The following is a description of a gene set: from publication Fu W, Ergun A, Lu T, Hill JA, Haxhinasto S, Fassett MS, Gazit R, Adoro S, Glimcher L, Chan S, Kastner P, Rossi D, Collins JJ, Mathis D, Benoist C (PMID 22961053) Human Gene Set: GSE40274_CTRL_VS_FOXP3_AND_HELIOS_TRANSDUCED_ACTIVATED_CD4_TCELL_DN Genes down-regulated in CD4 T conv: control versus over-expression of IKZF2 and FOXP3. The transcription factor FoxP3 partakes dominantly in the specification and function of FoxP3+ CD4+ T regulatory cells (Tregs), but is neither strictly necessary nor sufficient to determine the characteristic Treg transcriptional signature. Computational network inference and experimental testing assessed the contribution of several other transcription factors (TFs). Enforced expression of Helios or Xbp1 elicited specific signatures, but Eos, Irf4, Satb1, Lef1 and Gata1 elicited exactly the same outcome, synergizing with FoxP3 to activate most of the Treg signature, including key TFs, and enhancing FoxP3 occupancy at its genomic targets. Conversely, the Treg signature was robust to inactivation of any single cofactor. A redundant genetic switch thus locks-in the Treg phenotype, a model which accounts for several aspects of Treg physiology, differentiation and stability. species: Homo sapiens, and this is the list of marker genes: MAP3K7, POLD2, C15orf39, TMTC4, TMEM39A, DNAJC1, SEC11C, NODAL (nodal growth differentiation factor), TFG, DPAGT1, UCK2, TMEM214, PRDX6, BUB1B, NCAPH, CCND2, ATF6, ARL5A, KDELR2, PALS2, TIMM21, PLP2, SLC12A2, PNPO, STAMBP, RGCC, DNAJC10 (DnaJ heat shock protein family (Hsp40) member C10), DUT, AP1S1, OSTC, CD300LF, TRPT1, ITFG1, GNG12, ZWILCH, BST2, PPP3CC, PRDX4, STARD5, ALG3, NSDHL, PRLR, CLPTM1, UBFD1, UBA5, TTLL12, UBAC2, GNL3, IRF4, ERO1A (NCBI Gene Id 30001), LGALS3BP, GOT2, SDC1, GSTT1, PSMD14, PSMB5, PKM, CRLS1 (NCBI Gene Id 54675), SARAF, USO1, SEC23B, TMED3, SELENOK, TMEM184B, NMT1, UBXN4, PARPBP, SPC25, ZNF280B, PLA2G6, CIP2A, GAS2L1, NCAPH2, YIF1B, ARMCX3, STARD3NL, IGKC, MYDGF, TMEM165, MAN2A1, KCNK6, ALDH7A1, DDOST, PHF10, SRP54, REXO2, DAD1, NDUFAB1, CMC2, TBL2, COPS4, CSF2RB, SEC61A1, APMAP, CDKN2C, TCF19, NUDCD1, TOP1, GANAB, SEL1L, DSCC1 (NCBI Gene Id 79075), ITIH2, EVC, LINC01160, ELL2 (NCBI Gene Id 22936), NANS, NUDT5, SRPRB, GINS1, PSMC3IP, PYY, UPB1, ARL13A, CDKN3, NMRAL1, ANLN, TIPIN (TIMELESS interacting protein), S1PR2, POMP, SSR4 (NCBI Gene Id 6748), TM9SF3, RFC4, ALPK2, ATF5 (NCBI Gene Id 22809), NUDT4, PYCR2, PLOD3, ZFP64, IMPA2, PGK1, SCFD2, EIF2B1, DMAC1, ABRACL, PIGK, MARCHF5, PTGR1, BPGM, LSS, RNF187, DERL2, KCNN4, CENPK, HROB, NARS1, LGALS1, LMO4 (LIM domain only 4), NCAPD2, DBI, PHGDH, HCFC2, PRPS1 (NCBI Gene Id 8254), CHID1, NEDD4, ST14, DHDDS, BET1, LMAN2, CDK5RAP3, PSMB8, APOO, TM9SF1, FARP2, NBEA, HSP90B1, MYL4, DERA, FTSJ1 (FtsJ RNA 2'-O-methyltransferase 1), DERL3, CDV3, PYCR1, IKBIP, GCOM1, GCAT, RNPEP, ATP2A2, CHAC1, SND1, SHMT2, COPS6, C14orf180, TEDC1, MAGT1, UTP6, RPS6KA2, CTH (cystathionine gamma-lyase), HSPA13, CYP4F22, EXO1, ENTPD7, DUSP22, PDIA6, TMEM248, CXCR3, NCAPD3, ALDH9A1, KIF11, PLAAT3, NIBAN1, VMP1